Given this list of marker genes Npffr2, Pnoc, Grk2, Gnao1, Pdyn, Gnas, Wls, Penk, Il2, here is a description of the gene set: Mouse Gene Set: GOMF_OPIOID_RECEPTOR_BINDING studied in species Mus musculus Binding to an opioid receptor.